Given this list of marker genes DUOX1 (dual oxidase 1), MAPK1, ZNF675, CKLF, CCR2, COMMD7, HNF1A, PAX6, MAPK9 (mitogen-activated protein kinase 9), AIMP1, MAPK11, here is a description of the gene set: BACKGROUND: Studies suggest that the recall-based humoral immune responses to influenza A/H1N1 originates from activated memory B cells. The aim of this study was to identify baseline, early and late blood transcriptional signatures (in peripheral blood mononuclear cells/PBMCs) associated with memory B cell response following influenza vaccination. METHODS: We used pre- and post-vaccination mRNA-Seq transcriptional profiling on samples from 159 subjects (50-74years old) following receipt of seasonal trivalent influenza vaccine containing the A/California/7/2009/H1N1-like virus, and penalized regression modeling to identify associations with influenza A/H1N1-specific memory B cell ELISPOT response after vaccination. RESULTS: Genesets and genes (p-value range 7.92E(-08) to 0.00018, q-value range 0.00019-0.039) demonstrating significant associations (of gene expression levels) with memory B cell response suggest the importance of metabolic (cholesterol and lipid metabolism-related), cell migration/adhesion, MAP kinase, NF-kB cell signaling (chemokine/cytokine signaling) and transcriptional regulation gene signatures in the development of memory B cell response after influenza vaccination. CONCLUSION: Through an unbiased transcriptome-wide profiling approach, our study identified signatures of memory B cell response following influenza vaccination, highlighting the underappreciated role of metabolic changes (among the other immune function-related events) in the regulation of influenza vaccine-induced immune memory. Human Gene Set: HARALAMBIEVA_PBMC_FLUARIX_AGE_50_74YO_CORR_WITH_28D_MEM_B_CELL_RESPONSE_AT_28DY_LEUK_MIGR_MAPK_ACT_CYTOK_SIG_DIAB_OF_THE_YNG_NEGATIVE Genes negatively correlated with memory B cell response at 28d in peripheral blood mononuclear cell in seniors (50-74) after exposure to Fluarix, time point 28D. Comment: selected pathways: leukocyte migration, MAP kinase activity, cytokine signaling, diabetes of the young species: Homo sapiens from publication Haralambieva IH, Ovsyannikova IG, Kennedy RB, Zimmermann MT, Grill DE, Oberg AL, Poland GA (PMID 27317456)